The following is a description of a gene set: Human Gene Set: GOBP_G1_TO_G0_TRANSITION A cell cycle arrest process that results in arrest during G1 phase, whereupon the cell enters a specialized resting state known as G0 or quiescence. studied in species Homo sapiens, and this is the list of marker genes: EZH2, TP53 (NCBI Gene Id 7157), ZBTB17, GATA6, SLC39A5, RNF112, CAPN3, RRP8, ZNF503, MYBBP1A, WDR6, STK11, ECRG4, CDK5R1, CYP27B1, SMPD3, RPL23, PHGDH, STRADA, RAB11FIP4